Given this list of marker genes PAN3, MARCHF3, NTRK2, RGS8, DGKA, RABGAP1, NEURL1B, PATL1, PPP3CB, SLC25A31, PFN2, PEG10, RARG, ARMCX3, HNRNPR, IGF1R, KDM3B, RAVER2, NAT8L, CDK6, SOCS6, CITED2, KMT2B, ARMH3, GPCPD1, GRIK3, SPATS2L, SLC45A3, RHBDF1, here is a description of the gene set: Genes predicted to be targets of miRBase v22 microRNA hsa-miR-885-3p in miRDB v6.0 with MirTarget v4 prediction scores > 80 (high confidence targets). studied in species Homo sapiens Human Gene Set: MIR885_3P from publication Chen Y, Wang X (PMID 31504780)